Given this list of marker genes Slc18b1, Azin2 (NCBI Gene Id 242669), Oaz1, Oaz3, Oaz2, Atp13a3, Slc22a1, Slc47a1, Slc22a16, Atp13a4, Ldc1, Azin1, Slc22a2, Pou2f2, Atp13a2, Atp13a5, Slc22a3, here is a description of the gene set: Mouse Gene Set: GOBP_POLYAMINE_TRANSPORT The directed movement of polyamines, organic compounds containing two or more amino groups, into, out of or within a cell, or between cells, by means of some agent such as a transporter or pore. species: Mus musculus